Given this list of marker genes CPB1, REEP4, SSTR1, NOTCH2, ADAMTS6, SCN7A, EMX2, COMMD3, CBLN1, PRDM8, CD58, VPS37A, DLX1, VASN, SIRT6, ZFHX3, TRERF1, GADL1, SUPT16H, CDK19, PPP1R10, TIMM10B (NCBI Gene Id 26515), TFR2, CFB, STAC2, CACNA2D3, SREK1, FBXO11, ERG, CD68, CCDC60, FGF5, DPYD, ZIC4, NUDCD1, HOXA2, HOXA3, IRAG1, PCDH10, CEACAM19, DLG2, XCL1, AXIN2, GEN1, HOXD10, ZBTB40, NHLH2, STAT5B, CHD2, BNC2, TOB1, PTPRC, PCDH7 (NCBI Gene Id 90855), MRPS18B (NCBI Gene Id 92039), CAMK2D, CNOT7, PDZRN4, WDR49, ANKRD2, TTR, SCT, PPM1L, CAMK1G, ENSG00000255537, TBR1, XCL2, RNF43, SLITRK2, PHACTR3, RAVER1, KIF19, SIAH3, HOXB8, ZNF143, RALYL, SLC6A9, MYT1, RPA3, COL4A4, ZBED10P, SYT4, NR2C2AP, OSBPL7, SPX, AP1G2, KRT85, TAPBP, SDCCAG8, VAX1, SMTN, FUT11, LRMDA, BMPR1B, NOTCH2NLA, YWHAZ, SLC18A2, NEUROG3, SLC17A6, PPP3CB, HNRNPUL1, MOSPD2 (motile sperm domain containing 2), CDHR5, ZMIZ1, DAB1 (DAB adaptor protein 1), SLC10A2, LIF, DRG1, PAX3, TAFA1, HOXB2, NR6A1, HNF4G, TBL1X, SERPINI2, TSHZ2 (teashirt zinc finger homeobox 2), PGM1, EDEM3, SWAP70, CSRNP3 (NCBI Gene Id 80034), MYPN, ACYP2, MRPS6, CYRIA, CHAT, SRSF7, SOX6, NEDD4L, ARHGAP15, KCTD15, ERBB4, ATG2B, GDF7, NANOS1, TINAG, ROBO3, GEMIN4, IRF9, THOC6, SLC43A3, PRRG4, CALCR, EMCN, CPNE1, WFDC2, IP6K2, ZIC1, CALD1, TCF7, MAP2K5, SMC6, REV1 (NCBI Gene Id 51455), SAMD1, NVL, COL4A3, SEPHS2, HCFC1R1 (NCBI Gene Id 54985), PRICKLE2, ZFPM2, AQP9, RARB, C19orf33, PRR34, EBF2, TBL1Y, ARSG, UCKL1 (NCBI Gene Id 54963), CARTPT, ANGPT1, ONECUT2, MITF, ZNF711 (NCBI Gene Id 7552), PTGER1, LIM2, PHF21A, NAP1L2, FANCB, AK8, GPC4, STMN1, JUNB, DDX6, UTS2R, PRL, ZBTB22, CELF4, ABRAXAS2 (NCBI Gene Id 96567), SIX6, FNDC7, ZIC2, SPACA9, BDNF, PTTG2, ID2, AQP5, CCER1, DUSP5, RBFOX2, SH3D21, COL4A5, SCHIP1, SLK, PAPPA, BEND4, CRNN, SKIDA1, ALDH16A1, CSF2, PRPF38B, CD226, ZNHIT2 (NCBI Gene Id 741), OLFML3, JARID2, ZNF532, SHC3, ROPN1, GSK3B, HOXD8, PBXIP1, SLC13A1, FAM117A, STT3B, GABARAP, LEF1, FGF13 (fibroblast growth factor 13), HLA-DOB, EHD4, SYT1, PREX2, NFIB, CIB3, FEZ1, GPX1, MSL2 (MSL complex subunit 2), NDP, CCND1, TLE4, SRRM4, LTBP1, AMBN, TMOD3, CCND2, HOXB9, IL1RAPL1, COL4A6 (NCBI Gene Id 1288), HOXA11, ELAVL2, JADE2, MBNL1, PHF23 (PHD finger protein 23), DUSP10, CNTLN, NLK, MYL2, PRDM13, HDAC9, SALL1, A1BG, KMT2A, KCNA3, DCX, here is a description of the gene set: Genes having at least one occurrence of the motif ANCAATCAW in the regions spanning 4 kb centered on their transcription starting sites. This matches the PBX1 transcription factor binding site V$PBX1_01 (v7.4 TRANSFAC). Human Gene Set: PBX1_01 studied in species Homo sapiens